The following is a description of a gene set: species: Homo sapiens Human Gene Set: GOMF_POTASSIUM_CHLORIDE_SYMPORTER_ACTIVITY Enables the transfer of a solute or solutes from one side of a membrane to the other according to the reaction: K+(out) + Cl-(out) = K+(in) + Cl-(in)., and this is the list of marker genes: SLC12A5, SLC12A7, SLC12A6, SLC12A8, SLC12A2, SLC12A1, SLC12A4, SLC12A3, SLC12A9